Given this list of marker genes Cdhr5, Ackr3, Myo6, Picalm, Ap1s1, Dgkd, Trf, Dnm2, Fcho2, Ap2a2, Adcy8, Tfap2a, Dab2, Epn3, Epn1, Ap2a1, Cltc, Fnbp1, Sele, Eps15, Btbd8, Bmpr2, Clta, Snx9, Arrb2, Amn, Cubn, Inpp5f, Ston2, Gas7, Tnk2, App, Dnm1l, Tbc1d5, Vldlr, Hspd1, Lrp12, Synj1, Slc18a3, Sgip1, Rab35, Necap1, Lrp1, Lrp2, Ap1g1, Ccdc32, Ldlr, Cltb (NCBI Gene Id 74325), Slc2a4, Cemip, Atat1, Ap1s3, Cttn, Arrb1, Ston1, Ocrl, Ap1s2, Bcl2l1, Eps15l1, Dnm1, Fcho1, Numb, Sort1, Sh3bp4, Reps1, Ap2b1, Fchsd2, Hip1r, Aak1, Itsn1, Lrp10, Snap91, Sphk1, Ap2m1, Ap2s1, Tfrc, here is a description of the gene set: Mouse Gene Set: GOCC_CLATHRIN_COATED_PIT A part of the endomembrane system in the form of an invagination of a membrane upon which a clathrin coat forms, and that can be converted by vesicle budding into a clathrin-coated vesicle. Coated pits form on the plasma membrane, where they are involved in receptor-mediated selective transport of many proteins and other macromolecules across the cell membrane, in the trans-Golgi network, and on some endosomes. species: Mus musculus